The following is a description of a gene set: species: Mus musculus Any process that modulates the frequency, rate or extent of the cellular response to osmotic stress. Mouse Gene Set: GOBP_REGULATION_OF_CELLULAR_RESPONSE_TO_OSMOTIC_STRESS, and this is the list of marker genes: Letm1, Ybx3, Bad, Cln3, Efhd1, Usp15, Micu1, Epo, Bdkrb2, Slc25a23, Tifab, Ptgs2